Given this list of marker genes LRP5, TSPAN12, P3H2, NDP, HLA-A, ZNF408, ARSK, ARL3, PAK2, FZD4, TTR, CTNNB1, here is a description of the gene set: studied in species Homo sapiens Vitreous floaters Human Gene Set: HP_VITREOUS_FLOATERS Deposits of various size, shape, consistency, refractive index, and motility within the eye's vitreous humor, which is normally transparent.